Given this list of marker genes MAPT, RRM2B, GSN, TTPA, PRNP, RNASEH1, here is a description of the gene set: species: Homo sapiens Human Gene Set: HP_SHORT_TERM_MEMORY_IMPAIRMENT Short term memory impairment A deficit in the retention of pieces of information (memory chunks) for a relatively short time (usually up to 30 seconds).